The following is a description of a gene set: studied in species Homo sapiens Psychotic mentation Human Gene Set: HP_PSYCHOTIC_MENTATION A pattern of thinking and perceiving characterized by a loss of contact with reality, leading to significant changes in thoughts, perceptions, and behaviors., and this is the list of marker genes: MT-TW, FIG4, CRH, MT-CO2, MTHFR, MT-ND5, CABP4 (calcium binding protein 4), MT-ND4, MT-CO3, CHRNA2, MT-TS2, MT-TH, MT-TQ, CHRNB2, MT-ND1 (mitochondrially encoded NADH:ubiquinone oxidoreductase core subunit 1), MT-TL1, MT-TF, KCNT1, DEPDC5, AIP, MT-CO1, GSS (NCBI Gene Id 2937), MT-ND6, USP8, CHRNA4, GRIN2A, FRRS1L, ALDH4A1